The following is a description of a gene set: Genes up-regulated in comparison of virus specific (gp33) exhausted CD8 T cells versus the virus specific (gp276) cells. studied in species Homo sapiens from publication Wherry EJ, Ha SJ, Kaech SM, Haining WN, Sarkar S, Kalia V, Subramaniam S, Blattman JN, Barber DL, Ahmed R (PMID 17950003) CD8 T cells normally differentiate from resting naïve T cells into function effector and then memory CD8 T cells following acute infections. During chronic viral infections, however, virus-specific CD8 T cells often become exhausted. We used microarrays to examine the gene expression differences between naive, effector, memory and exhausted virus-specific CD8 T cells following lymphocytic choriomeningitis virus infection. Human Gene Set: GSE9650_GP33_VS_GP276_LCMV_SPECIFIC_EXHAUSTED_CD8_TCELL_UP, and this is the list of marker genes: ATG2A, C1QC, FSTL1 (NCBI Gene Id 65385), SLC35E4, POLRMT, H1-5, ERCC5, COMTD1, FKBP10, PGR, TPK1, MITF, AFP, ENTPD7, SHOX2, TXNRD3 (NCBI Gene Id 93415), KRT27, SNAI1, SLC4A8, EFNB3, FOXO4, SUB1, SPIC, SAPCD1, ZNF821, CLRN3 (NCBI Gene Id 119467), FJX1, ZNF467, NDUFA1 (NADH:ubiquinone oxidoreductase subunit A1), FGF10, ARID3B, NR1H4, TNKS1BP1, RASGRF2 (NCBI Gene Id 89993), PRL, SURF4, TLR7, STRA6, GAPDHS, ZNRF1, IGFBPL1, HLA-DMA, GCM2, SERPINH1, CCL11, AOPEP, HTR2C, RORC, B3GALT4, SELP, TGM3, HAPSTR1, BRS3, CALML5, EGR2, ITIH4, ELK1, OGN, SPOCK1, PTPRO, CPS1, RPS14, CNIH2, HTRA1, CFH, PDGFRA, ADAMDEC1 (ADAM like decysin 1), NOP2, TGM2, CRISP2, MRPS2, GABRD, ACADVL, XCR1, ATP13A2, FHL1, MLLT1, TRO, COTL1, TRAPPC5, SARS2, RPP21, SFRP2, S100A8, APOBEC2, SHMT2, PRR15, CYP2F1, ALOXE3, FMO3, PAM, SALL4, BCAR1, DBP, DPPA2, H1-4, BAAT, PXMP2, BCL3, SLC11A1 (NCBI Gene Id 6556), SLC15A2, HMX3, ABCD2, ACE2, ARL8B, PHLDB2, EYA2, STIM1, SERPING1, TLN1, HOXD10, SIX2, ADA, TWF1, LIMA1, YAP1, DOCK7, LRP10, TLE5, CXCL14, CANX, COL19A1, TRPC1, MEOX1, ITIH1, MCAM, HSPA4L, AGAP1, DPT, PLA2G4A, SAG, CLDN11, CP, ZNF799, HAO2, ZKSCAN3, CTSK, PTPN12, PDLIM7, PCDHA12, SEPHS1, S1PR3, ERCC1, CIZ1, KCNAB1, GDNF, CACNA1G, FGF1, LPP-AS2, SCGB1A1, ZFP28, DMP1, LY86, WIZ, CMBL, DDRGK1, DYNC1I1, NDUFA13, PLA2G10, INPPL1, MYH2, IL1A, SCN7A, HCFC1R1, SMAD7, TYROBP, PADI1, HSD3B7, MAGEL2, RGS16, FRK, GMPPB, FIGLA, CPLX2, RNF123, TSPAN13, IGF2, MRC1, DPP7 (dipeptidyl peptidase 7), SIM1, GABRB2 (NCBI Gene Id 2561), WNT2B, ANXA3, CSK, P4HA2, DAZAP1 (DAZ associated protein 1), NAP1L2, C1orf52, POU2F2, PTPRJ, SF3A1, LGMN, CKMT1B (creatine kinase, mitochondrial 1B), CADPS, KHK, ZDHHC9, CARM1, AFF4, GPX2, KLF5